Given this list of marker genes Abca1, Apoc4 (apolipoprotein C-IV), Apoa4, Prkacb, Apoc1, Apoa2, P4hb, Apoa1, Apoc3, Apoc2, Apob, Bmp1, Prkaca, A2m, Apoe, here is a description of the gene set: This event has been computationally inferred from an event that has been demonstrated in another species.<p>The inference is based on the homology mapping from PANTHER. Briefly, reactions for which all involved PhysicalEntities (in input, output and catalyst) have a mapped orthologue/paralogue (for complexes at least 75% of components must have a mapping) are inferred to the other species. Reactome Pathway: Plasma lipoprotein assembly electronically inferred by orthology from the curated human pathway species: Mus musculus part of: Plasma lipoprotein assembly, remodeling, and clearance